The following is a description of a gene set: Stops, prevents or reduces the activity of any enzyme that catalyzes the hydrolysis of GTP to GDP and orthophosphate. species: Homo sapiens Human Gene Set: GOMF_GTPASE_INHIBITOR_ACTIVITY, and this is the list of marker genes: GPS1, CDC42SE1, PDE6D, CPEB2, TNK2, SLIT2, RHOH, IQGAP2, GPS2, IPO5, IQGAP1, RTKN